Given this list of marker genes Mbd2, Ywhag, Trim34a, Rab10, Atp10a, Cyp1a1, Plcb1, Art2a, Sntb1, Dtna, 4930461C15Rik, Fam199x, H1f7, here is a description of the gene set: Genes down-regulated in small intestine upon loss of both APC and MBD2. from publication Phesse TJ, Parry L, Reed KR, Ewan KB, Dale TC, Sansom OJ, Clarke AR (PMID 18644872) studied in species Mus musculus We have previously shown that deficiency of the methyl binding domain protein Mbd2 dramatically reduces adenoma burden on an Apc(Min/+) background. To investigate the mechanism underlying this phenomenon, we have determined the effect of Mbd2 deficiency upon the phenotypes imposed by the conditional deletion of Apc in the small intestine. Microarray analysis demonstrated a partial suppression of the Wnt pathway in the absence of Mbd2. Mbd2 deficiency also influenced one immediate cellular consequence of Apc loss, with normalization of Paneth cell positioning. From a mechanistic perspective, we show that deficiency of Mbd2 elevates levels of the known Wnt target Lect2, and we confirm here that Mbd2 binds the Lect2 promoter in association with NuRD. Furthermore, we show that Lect2 is capable of functioning as a Wnt pathway repressor. These results therefore provide a mechanistic basis for the epigenetic control of adenoma formation mediated through Mbd2. Mouse Gene Set: PHESSE_TARGETS_OF_APC_AND_MBD2_DN